Given this list of marker genes GASK1B, OR10D3, WWTR1, SLC38A9, SNORA78, ZC3HAV1L, LPCAT4, RAB11FIP5, RHEBL1, CFH, MPP1, CLIC5, FBXO30, CTSC, ZFYVE1, PROP1, WIPI1 (NCBI Gene Id 55062), CFHR2, CCL5, MSC-AS1, IFNGR1 (interferon gamma receptor 1), SLC44A3, PERP, COLQ, MAP7D3, LZTFL1, APOBEC3G, ANXA2P3, EPS15, ZNF555, HOMER2, ELOVL6, METTL1 (NCBI Gene Id 4234), PLCB1, WNT10B, ADAM8, ONECUT1, TMEM41A, AFDN, ARL15, GAB3, ZNF490, PRNP, PPP2R2B, DLGAP2, RARG, RGS18, CDC42EP1, MICAL2, KIF21A, S100A4, PLOD3, MNAT1, PRR5, MYBL1, LRATD2 (NCBI Gene Id 157638), ZNF513, S100A2 (S100 calcium binding protein A2), NKAPD1, KATNAL1, SPIRE2, SNX15, ZFYVE28, ZNF568, HLF, KIT, EAF1, LGALS3, PLEK (pleckstrin), FSD1L, ZNF532, SPOCK1, CDC42EP3, CYFIP1, FERMT2, MIPEP, RBKS, ABCB1, GPR68, EOMES (eomesodermin), ANXA2, LTK, PRCP, ANXA2P2, ACSL6, RORC, TBC1D19, DSE, SAMSN1, ANXA2P1, STOM, FAR2, PLEKHG1, ATP2B4, COL4A4, LMNA, SFXN3, OGFRL1, LRRFIP1, RGMA, AHR, DUSP8, EFCAB6, ANKRD28, SLC20A1, LGALS1, TPBG, MLF1, TYW5 (tRNA-yW synthesizing protein 5), TMEM185B, PDE4A, CD58, LRP12, CCR6, THEMIS, CEP112, ZNF438, DIAPH1, CYB561, LINC02891, B3GALNT2, XPR1, FBXO36, PJVK, ASB2, PROK2, AGO4, ADRB2, CTAGE1, SLC35B1, C3orf33, VKORC1L1, VCF1, CTNNA1, EPAS1, ALX3, PAM, ZNF2, CTDSP1, ZSCAN9, GJA10, DMRTA2, FBXW5, GRIA3, TMEM39A, CIRBP-AS1, GFI1, HABP2 (NCBI Gene Id 3026), ATP1B1, HOPX, CXXC1P1, MAN1A1, VCL, GALNT4, CARS1, CAST, PHLDA1 (pleckstrin homology like domain family A member 1), CCR9, SLK (NCBI Gene Id 9748), GRID1-AS1, RNF207, MATCAP1, KAT2B, RASGEF1A, GVQW3, CCZ1, TNFSF14, HSD11B1, STING1, SMKR1, CHSY1, ATP12A, TIMP1, FMO5, GPR65, HIC1, ARL13B, SLC36A1, CYP27B1 (NCBI Gene Id 5135), MTFR1, B3GALT2, TMEM163, ACTN4, FAM110C, RHOU, STX3, ENPP5, NPC1, ATAT1, TBK1, SEPTIN11, MAPK7 (mitogen-activated protein kinase 7), EFHD2, TOR4A, SLF1, MMD, CLU, COL5A1, here is a description of the gene set: species: Homo sapiens Human Gene Set: GSE11057_EFF_MEM_VS_CENT_MEM_CD4_TCELL_UP from publication Abbas AR, Wolslegel K, Seshasayee D, Modrusan Z, Clark HF (PMID 19568420) Microarray deconvolution is a technique for quantifying the relative abundance of constituent cells in a mixture based on that mixture's microarray signature and the signatures of the purified constituents. It has been applied to yeast and other systems but not to blood samples. Here we test the ability of this technique to determine the fractions of subsets of memory T cells in peripheral blood mononuclear cell (PBMC) samples. Genes up-regulated in comparison of effector memory T cells versus central memory T cells from peripheral blood mononuclear cells (PBMC).